Given this list of marker genes CTSW, KLRF1, KLRC1, NKG7, SESN1, GNLY, KIR3DL2, KIR3DL3, DLG5, PRSS23, KIR2DS4, GZMB, NCAM1 (NCBI Gene Id 4684), APBA2, XCL1, KLRB1, KIR3DL1, BCL2, BACH2, NELL2, IRF8, CCL4 (NCBI Gene Id 6351), HOPX, KDM2A, CD160, VAV3, IL2RB, PTCH1, MYBL1, TRDC, GZMK, DUSP2, TXK, CCL5, ZBTB16, SERPINB9 (NCBI Gene Id 5272), BST2, IL18RAP, TSPAN13, SPON2, ADGRG1, KLRD1, MATK, here is a description of the gene set: PURPOSE: Increased production of Th2 cytokines characterizes Sezary syndrome, the leukemic form of cutaneous T-cell lymphomas (CTCL). To identify the molecular background and to study whether shared by the most common CTCL subtype, mycosis fungoides, we analyzed the gene expression profiles in both subtypes. EXPERIMENTAL DESIGN: Freshly isolated cells from 30 samples, representing skin, blood, and enriched CD4(+) cell populations of mycosis fungoides and Sezary syndrome, were analyzed with Affymetrix (Santa Clara, CA) oligonucleotide microarrays, quantitative PCR, or immunohistochemistry. The gene expression profiles were combined with findings of comparative genomic hybridization of the same samples to identify chromosomal changes affecting the aberrant gene expression. RESULTS: We identified a set of Th1-specific genes to be down-regulated in Sezary syndrome as well as in a proportion of mycosis fungoides samples. In both Sezary syndrome and mycosis fungoides blood samples, the S100P and LIR9 gene expression was up-regulated. In lesional skin, IL7R and CD52 were up-regulated. Integration of comparative genomic hybridization and transcriptomic data identified chromosome arms 1q, 3p, 3q, 4q, 12q, 16p, and 16q as likely targets for new CTCL-associated gene aberrations. CONCLUSIONS: Our findings revealed several new genes involved in CTCL pathogenesis and potential therapeutic targets. Down-regulation of a set of genes involved in Th1 polarization, including the major Th1-polarizing factor, TBX21, was for the first time associated with CTCL. In addition, a plausible explanation for the proliferative response of CTCL cells to locally produced interleukin-7 was revealed. studied in species Homo sapiens Human Gene Set: HAHTOLA_SEZARY_SYNDROM_DN Genes down-regulated in monocytes isolated from peripheral blood samples of Sezary syndrom patients compared to those from healthy normal donors. from publication Hahtola S, Tuomela S, Elo L, Häkkinen T, Karenko L, Nedoszytko B, Heikkilä H, Saarialho-Kere U, Roszkiewicz J, Aittokallio T, Lahesmaa R, Ranki A (PMID 16914566)